Given this list of marker genes ATL1, BNIP1, ATL3, ATL2, VCPIP1, here is a description of the gene set: The joining of 2 or more lipid bilayer membranes that surround the endoplasmic reticulum. Human Gene Set: GOBP_ENDOPLASMIC_RETICULUM_MEMBRANE_FUSION species: Homo sapiens